The following is a description of a gene set: Human Gene Set: GOBP_NEGATIVE_REGULATION_OF_RNA_METABOLIC_PROCESS Any process that stops, prevents, or reduces the frequency, rate or extent of the chemical reactions and pathways involving RNA. studied in species Homo sapiens, and this is the list of marker genes: ZNF425, NR1H3, ZFHX3, PFDN5, TRIB1, CREG1, CAV1, BRCA1, ZMYM2, DNAJB5, TBR1, RBM42, ALX1, ACTRT1, MORC1 (NCBI Gene Id 27136), SOX4, OTP, ZNF589, TAL1, TXNIP, POU3F3, KLF5, HCLS1, NR2C1, CRY1, CUL3, TAF9B, RNH1, IKZF4, TLE3, TWIST1, TRPV4, MEPCE, FOXP3, PRDM6, PTPN2, JUN, ZNF254, OGT, USP2, PARP14, HOXB13, HEYL, FBLL1, RBM10, TENT4B, DMAP1, MAGEA11, SOX13, CBX2 (NCBI Gene Id 876), SRSF4, ZNF536, IGF2BP2, BCL6B, CITED1, ZHX3, PITX2, ZNF205, NUDT16, GATA1, IGBP1, CCND1, ZFP36, ZNF559-ZNF177, ZBTB20, IL4, DEAF1, MYC, TSHZ3, YBX3, MBD3, HHEX, RBM15B, CIPC, ATF5, ZNF777, WWTR1, ZNF140, PLK1, BRD7, MAGEA2B, HOXA2, NR2F6, TBL1XR1, EP300, FOXC1, YWHAQ, HAND1 (NCBI Gene Id 9421), HNRNPL, MEN1, HES5, JARID2, ZC3H8, SOX7, CTBP1, MYOZ2, ESR2, RBPJ, KAT6A, MAGED4B, FOXH1, TRIM29, RBL1, SMAD3, MIER1, DAZL, ZBTB8A, APBB2 (amyloid beta precursor protein binding family B member 2), SIX5, MAGEA1 (NCBI Gene Id 8271), RBBP4, MTDH, SLIRP, ASCL1, CHD8, LARP1, MAGEA4, HOXB3, NFIL3, SPINDOC, IMPACT, TLE7, CD38, SPEN, L3MBTL2, GLIS3 (GLIS family zinc finger 3, NCBI Gene Id 648268), JPH2, HDAC3, WWP2, YWHAZ, LANCL2, CDX4, PRAMEF9, DLX1, TPR (NCBI Gene Id 7175), RIOX1, SFRP4, LMCD1, ZBTB38, SMO, ZBTB33, TRDMT1, CDKN1C, SINHCAF, MCPH1 (microcephalin 1), MTA3, BCOR, PRICKLE1, IKBKE, CDY2B, CBFB, DDX54, AMOTL2, PKP3, ZNF217, USP9X, ATF3, NPAS1, MAGEA9, KDM8, PARP9, RARA, ZNF263, BMP6, PDE2A, TENT2, HOPX, BASP1, TBL1Y, ZAR1 (NCBI Gene Id 326340), TNF, PRDM12, TBX22, PAWR, MAGEA8, ZIC2, TBX15, HDGF, DCAF1, ZNF85, IRF7, HOXB8, MBD3L3, SREBF2, FLYWCH1, SKOR1, MXI1, PRAMEF12, RTF1, KLF10, SMARCA2, SUPT4H1, BCLAF1, SPI1, MBD3L2B, PAX9, LARP7, KLF3, AXIN2, HEY1, KAT2B, NFIB, SRF, ATP8B1, NKX6-2, NONO, ZMYND8, MAFG, PHC3, SIAH2, EID2B, NFATC4, HNRNPA0, WWC2, BHLHE41, ZBTB32, IRF2, POU1F1, CDK6 (NCBI Gene Id 1021), PABPC1, NPAT, MAX, HOXC8, MAGEA6, PAIP1, MIR128-1, SHH, TRIM11, ATXN1, ZKSCAN3, NMNAT1, SUV39H2, LDB2, NKX6-1, SETD5, SFMBT2, TFEC, WWP1, DMRT1, CENPF, TNFSF11, PRDM8, ACTR6, CEBPB, SFPQ, CDY2A, PAX5, ETV6, BMP7, SCRT1, PHF19, EZR, SHOX2, EED, FOXL2, PHF24, SNAI1, ZMYM5, ZBTB14, PPM1F, HSPA1A, DICER1, ZNF219, WWC1, TFAP2C, PRAMEF22, DNAJB4, SIRT6, SARNP, KAT14, LIMD1, GPS2, SBNO2, CRYM, ELAVL1, RIF1, MIER3, SIX3, HNRNPC, CTNNBIP1, CIC, SMAD2, MAFF, PSMD10, MAGEA10, PRDM1, RBM20, YAF2, ENO1, SP100, BTAF1, MAF (NCBI Gene Id 4094), ARID5A, RN7SK (RNA component of 7SK nuclear ribonucleoprotein), SDR16C5, TRIM6, PSPC1, TCF21, CNOT1, ARK2N, ZNF177, PRKN, LEF1, CXXC5, FZD1, NR2C2, CELA1, SMARCA5 (SWI/SNF related, matrix associated, actin dependent regulator of chromatin, subfamily a, member 5), SOX10, NBAS, TRAF3IP2, PCBP4, CIR1, VSX2, TAF3, LMO4, THRA, ZNF282, ZNF281, YWHAB, TFAP4, SFSWAP, CHD4, ZNF174, BAZ2A, FNIP2, CC2D1B, VEGFA, KDM2B, RBM38, VHL, SRSF1, CDK2, SCAF8, ZNF93, BHLHE40, ZBTB2, SATB1, QKI, SP5, BEND5 (BEN domain containing 5), IRX1, STRN3, SRSF2, HDAC4, FOXO3, DEPDC1, FOXG1, HMX1, FOXR1, PRDM14, SIN3A, SNCA, ZNF512B, CTBP2, GATAD2A, VAX2, CREB1, PEG3, HDAC9, HNRNPD, GLIS1, FOXC2, AR, COMMD7, RNF168, SMURF2, HMGB1, BPTF, AJUBA, POU4F1, IRF1, SUV39H1, WTIP, ZC3H14, JUND, CPEB3, RORC (RAR related orphan receptor C), NEUROG3, MAP2K5, SETDB2, MAD2L2, FUS, FOXD1, POU2F1, WFS1, MXD3, EPO, NELFB, NR1D1, ZP3, HINFP, TOB1, ZNF12, FASLG, FOXM1, CIITA, GATAD2B, TBX2, ZHX2, UBE2D1 (ubiquitin conjugating enzyme E2 D1), MAGEA2, ZBTB18, HES1, PPM1A, ZFTA, SMARCE1, BRMS1L, FOXJ1, ZNF296, PLA2G10 (NCBI Gene Id 8399), PAX2, ISL1, TWIST2, PRAMEF18 (NCBI Gene Id 391003), LRPPRC, TET1, KLF11, ZNF304, MAP3K10, ETS2, SOX1, ZNF608, NRARP, ANKRD2, FZD6, DND1, CTR9, SRC, NSD1, KMT5A, MESP1, SOX8, ZBTB16, TRIM37, TADA3 (transcriptional adaptor 3), RUNX2, SCML1, E2F8, EZH2 (enhancer of zeste 2 polycomb repressive complex 2 subunit), L3MBTL1, NFATC3, TARDBP, TRIM22, MAGEB6B, EN1, HIF1AN, TENT4A, PHB1, ZBTB4, PRAMEF19, SOX6, FEZF1, PKIG, NFATC2, SOX21, IRF2BP1, E4F1, DDX20, HNF4A, ANKRD1, XBP1, ZBTB34, SET, RELA, PRDM13, DNMT3B (DNA methyltransferase 3 beta), GATA4, YY1, CDK5R1, MYOCD, PCGF2, DEDD, RORB, RFX3, TCF7, CIRBP, DUSP22, SPDEF, TRERF1, TRAF2, CAPN3, ZNF175, MED25, MAGEB17 (NCBI Gene Id 652862), PPP1CA, KLF2, SOX3, PBXIP1, POU6F1 (POU class 6 homeobox 1), ARID5B, SSX1, SOX9 (SRY-box transcription factor 9), ZCCHC17, FST, PAF1, ZNF438, FOSB, MOSPD1, SUMO1, KDM4A, GATA5, ATOH8, CRY2, NAB1, BAHD1, MAGEC2, IFI16, CUX1, RBBP7, BCORL1, MAGEB1, NR1I3, SIRT1, SHC1, CHD3, L3MBTL4, EID2, GATA6, APOBEC3A, THAP5, MDFI, DKC1, RNF2, BCL3 (BCL3 transcription coactivator), NR0B2, VPS72 (vacuolar protein sorting 72 homolog), MXD4, TENM2, SCMH1, APOBEC3B, THAP7, HNRNPAB (heterogeneous nuclear ribonucleoprotein A/B), HMGA2, MEF2A, CDYL2, HIVEP1, CNOT2, HEXIM1, NUPR2, TBXT, KLF12, TGIF2LY, THRB, THAP1, WNT5A, RASD1, TLE1, PML, ZBTB25, AURKB, MTA2, DKK3, MEIS2, MTA1, HEY2, SCRT2 (scratch family transcriptional repressor 2), DNAJB1, PPARD, NR1H4, ZNF692, DNAJB6, ZGLP1, ATF7, LEFTY1, MAGEA9B, HMBOX1, BACH2, FOXN3, CUX2, FBLN5, GREM1, CASP8AP2, NCOA2, N4BP2L2, IRX4, CCND3, LHX9, HES6, RITA1, FOXK2 (NCBI Gene Id 84213), ZNF451, MECP2, LIMS1 (LIM zinc finger domain containing 1), PAX6, IRF8, MBIP, SMYD1, NELFA, RIPPLY1, CALCA (NCBI Gene Id 87044), MAGEB5, ING4, ZNHIT1, SCAI, PRDM2, TFCP2L1, IGF2, PPHLN1, MAFK, KHDRBS1, ZNF397, FOXA2, HDAC6, CTCF, ZNF318, NFE2L3, DLL4, DRAP1, HEXIM2, NR2F1, NAF1, NFX1, TAF1, SFRP1, ELK3, PRAMEF26, PIAS1, NR1I2, IGF2BP1, PTBP1, CREBBP, ZNF675, GLI2, MAPK14, LHX1, DAZ4 (NCBI Gene Id 57135), MAGEB3, SIRT2, EZH1, APP, SIM2, SCAF4, AEBP2, HSF1, L3MBTL3 (NCBI Gene Id 84456), ASCL3, KDM5C, PARP10, RCOR3, KLF16 (NCBI Gene Id 83855), NODAL, CDKN2A, ZNF668, SKI, PSMC5, NACA, MZF1, SDCBP, LYAR, PRDM11, RPL23, ESR1, MMP12, COPS2, NANOG, CBX3, NFKB1, PHC2, NSMCE3, TRPV1, PCGF6, PURA, DDX5 (DEAD-box helicase 5), HIC2, PDCD4, SATB2 (SATB homeobox 2), ZNF683, FHL2, PTPRC, MORC3, TAF7, TBX18, RNF8, NFIC, EPC1, DACH1 (NCBI Gene Id 1602), OSR1, AICDA, ZNF431, SOX14, MBD2, E2F7, NCK2, SUMO4, RBM24, NOP53, FOXP1, ZNF750, TENT5A, PER2, RPS14, NELFCD, DHX9, ZNF136, ZBTB49, NCOR2, IFNL1, TDG, PRAMEF13 (NCBI Gene Id 400736), TBX3, TCEAL7, ZNF568, DAB2IP, MAGEF1, NDN, NR2E3, ACE2, ZSCAN10, FAM220A, SIRT7, BCL6, IKZF1, ZBTB17, FOXK1, PRDM5, METTL1, MAGEB10, ZFP90, FOXF1, MBTD1, PPP1R10, ZNF423, RERE, HSBP1, RIPPLY3, H3C13, YAP1, PRAMEF17, ELAVL4, LMO1, ZMYND15, RUNX1, MYBBP1A, MAGEE1, PTPRK, PRAMEF33, RCOR2 (NCBI Gene Id 283248), RB1, WT1, NR1H2, NOSTRIN, MAPKAPK2, PRAMEF14, DDIT3, DACT1, CREM, BAP1 (BRCA1 associated deubiquitinase 1), TBL1X, FAM220BP, ZBED2, UBE2I, IRF2BPL, MBD3L1, ING2, KDM1A, UBE2D3, ATXN1L, SOX15, SAP130, KLF8, EHMT1, E2F6 (NCBI Gene Id 1876), HAMP, PCGF1, PER1, CDY1B, NACC2, RSF1, MDM4, BOLL, CDYL, CNOT7, ZC3H12A, SOX2, MYOZ1, XPO1, TLE5, MACROH2A2, NCK1, CGGBP1, CALR, ZBTB12, TBX20, PRAMEF7, ERN2, ZNF256, PRNP, BMI1, DR1, PROP1, ATF2, TMPRSS6, EAPP, SMYD2, MED1, NR0B1 (nuclear receptor subfamily 0 group B member 1), MEIOC, DMBX1, PPARA, HELT, SIX4, HR, ZNF224, HSPA8, CBY1, MNT, ZFP92, DAB2, PRMT6, NRIP1, SCGB1A1 (NCBI Gene Id 7356), REST, TRIM28, ZNF639 (NCBI Gene Id 51193), DNAJA3, SNW1, H3C14, FOXE1, NPM1, DHX34, EDN1, RBMX, PRDM16, SMAD7, INPP5K, UPF3A, CCNE1, GCLC, IGF2BP3, RARG, APOBEC3C, MAGEA12, BMAL1, VGLL4, ELF3, INSM1 (NCBI Gene Id 8196), SOX18, AHR, FGF9, FOXO1, OLIG3, ZNF703, CDC73, PRAMEF4, MAGEL2, MACROH2A1, WNT10B, OVOL1, MAGED2, FABP4, FCN3, ZNF24, ESX1, TOB2, NOCT, IRF3, WDTC1, TFDP2, CBX8, TBX6, SAP30, ZNF148, ZNF274, E2F1, MBD3L2, CDK5, ID4, ARID4A, TENT5B, LIN37, APOBEC3H, TNP1, PHF12, HIC1, ZNF541, KAT5, POU5F1, CCAR2, EHMT2, SRSF7, ELANE, FOXA1, RFX5, DAZ1, ARID4B, ZC3H6, NKX3-2, ANGEL2, HOXB4, BTG2, ZBTB7B, NR2F2, RARB, CEBPA, LOXL2, CITED2, NFIX, HES2, VDR, NOTCH3, FBP1, ZNF133, RLIM, CSDE1, SORBS3, GZF1, ZNF8, HDAC7, SKIL, MAGEA3, PCNA, ZNF134, PRAMEF8, HSF5, NR4A2, PRAMEF2, VIP, PRMT5, KCNIP3, IREB2, ZBTB10, KCTD1, SAMD11, ZGPAT, CREB3L1, MYT1L, CBX6, SMARCC2, RECQL5, QARS1 (glutaminyl-tRNA synthetase 1), CBFA2T3, SOX12, TCERG1, SOX30, PHF14, MAGEE2, PHF21A, H1-5, KLF7, APOBEC3F, APBB1 (amyloid beta precursor protein binding family B member 1), BCL11A, CCAR1, SRSF6, UXT, TCFL5, HES7, ZEB1, AEBP1, DLX2, NICOL1, RBFOX2, MBD3L4, SF1, LBH, NAB2, NR2E1, RIOX2, ASAH1, TFAP2A, ARX, MAGEB16, PRRX1, SARS1, CTNNB1, BTRC, NELFE, POU4F2, HDAC1 (histone deacetylase 1), PWP1, TRIM33, NOTCH4 (NCBI Gene Id 4855), SOX11, RALY, ZNF366 (zinc finger protein 366), NKAP, NDUFA13, PASD1, COQ7, PDGFB, GATA2, BAG4, THAP11, TRIM27, MAF1, ZNF253, PPID, SGF29, CDKN1B, CDY1, GFI1, ZEB2 (NCBI Gene Id 9839), SFN, SNAI3, WDR82, PATZ1, KAT6B, HOXA7, BIN1, PHB2, TP53, NR1D2, RXRA, EN2, MSC, DNMT3L, DEDD2, CBX1, ZNF239, UIMC1, SALL4, CC2D1A, TIMELESS, SIK1, EOMES, JAZF1, MLIP, RUNX3, HMGB2, PER3, ASCL2, ZC3H4, ZFPM2, TSG101 (tumor susceptibility 101), CREBZF, RPL10, RUNX1T1, TGIF1, MBD3L5, MAGED4, EDNRB, MLXIPL, TP63, SCX, RCOR1, TRPS1, HMGA1, MIER2, TLE6, MDFIC, GATA3, DLG1, TENT5D, HBZ, LOXL3, BIRC5, PCBP3, KAT2A, TCF7L2, NCOR1, RNPS1, TGIF2LX, ZBTB26, ZHX1, MAGEB2, MYD88, PRAMEF6, DHX36, AASS, STAT1, MEF2C, NOTCH1, IL33, LEP, PRAMEF11, TRIB3, SIX1, GAS6, EGR1, ETV5, BRMS1, XRCC5, ID3, SRSF9, FERD3L, FNIP1, SMAD4, ERF, PPP1R13L, MAFB, NCOA5, IRX3, STAT3, PRAMEF5, SCML2, PROX1, HNRNPK, MAGEB18, RING1, CNBP, ANXA4, ZNF354C (zinc finger protein 354C), MSX1 (NCBI Gene Id 4487), URI1 (NCBI Gene Id 8725), UHRF1, SMARCA4, TLE2, S100A1, PIAS4, STAT6, PRDX5, DNMT3A, CRYAB, NR3C1, SYNCRIP, DAZ2, SUDS3, FOXD3, RFC1, MXD1, HDAC2, NACC1, PHAX, XCL1, CBX5, PLK3, CREBRF, KANK2, HCFC2, NOTCH2, NRIP2, NRG1, SREBF1, MITF, ZNF354B, SRSF10, ZMYND11, PARP1, THRAP3, KDM5B, HESX1, SQSTM1, PDX1, PPARG (peroxisome proliferator activated receptor gamma), RUVBL2, ZNF706, BARD1, RELB, RBM47, NSD2, DYRK1A, MAGEH1, ZNF827, SMAD5, ACVR2B, RPS6KA5, FAM76B, KEAP1, H1-2, ZNF268, PKIA, PA2G4, DAXX, SAP18, H1-3, SCML4, HSF4, JDP2 (NCBI Gene Id 122953), SNX6, GSTP1, HDAC5, MTERF3, H3C15, METTL16, MBD1 (methyl-CpG binding domain protein 1), FOXS1, TMBIM6, SMTNL1, PKP1, PRAMEF25, ZNF396, CDX2, MYB, GABPA, ZNF202, GLI3, ZNF540, RIPPLY2, PTCH1, FRK, BATF3, MAGEA13P, IFI27, PSEN1, WWC3, RBM15, HNF1B (HNF1 homeobox B), ZBED6, GDNF, CEBPD, TRAF6, YBX1, MLX, BEND6, ETV3, ZFPM1, MDM2, FOXP2, SP3, MUC1, MYPOP, TAGLN3, FLNA, XRCC6, CIART, BARX2, C1D, TCF3, ZNF418, DPF2, HSBP1L1, ATF4, FGFR2, APOBEC1, METTL14, TENT5C, CCDC85B, MNX1, ZBTB7A, PLAGL1, ZNF350, TCF23, SUZ12, LILRB4 (leukocyte immunoglobulin like receptor B4), RBM46 (RNA binding motif protein 46), PRMT2, EID1, ADIPOQ (NCBI Gene Id 9370), YEATS2, TRIM24 (tripartite motif containing 24), HOXD8, EREG, TGFB1, RREB1, TDP2, CBX4, OLIG2, GADD45A, NIPBL, SAMD7, ZBTB1, BACH1, SAP30L, MYF6, ZNF488, SFMBT1, IFNA2, CBFA2T2, GSC, ZBTB37, LDB1, ZNF141, OSR2, ILF3, PHC1, PARN, ACIN1, HJV, ZBTB21, ZBTB5, KCTD15, DAZ3, KLF4, ENG, ZBTB39, PRAME, ATF7IP, TFAP2B, MAGED1, ZBTB45, GMNN, SUFU, ID1, GFI1B, PARP15, CBX7, A1CF, ELK4, MSX2, PURB, NKX6-3, RYBP, HNRNPU, NR6A1, RRP8, FOXQ1, TSC22D4, IRX2, SP2, SEMA4D, LARP1B, FOXP4, TBX21, ESRRA, KDM5A, ZNF469, MECOM, CLOCK, CTNND1, ZBTB6, MAEL, ELF2, HCFC1 (NCBI Gene Id 8267), HMG20A, LARP4B, EFNA1, MAGEB6, WDR5, NRDE2, NKX2-5, ATN1, HDAC10, CSF2, TNFRSF4, NIBAN2, MIDEAS, DNMT1, ING1, RBAK (NCBI Gene Id 57786), ZNF746, NSUN2, SLA2, HIF1A (NCBI Gene Id 3091), SUPT5H, SFRP2, TRAF5, PRAMEF1, SECISBP2, NKRF, TGIF2, KDM2A, OTUD7B, MAGEB4, DUSP15, PRAMEF27, HDAC8, HOXD9, BMP4, APOBEC3G, ZNF653, SNAI2, OVOL2, HIRA, ZNF131, AMOT, NEDD4, ZNF658, ZNF91, H1-4, SRSF12, INSM2, IFNG, PEX14, AXIN1, NOC2L, NKX3-1, ZNF345, MDFIC2, PLCB1, NR4A3, SIN3B, SALL1, GTF2IRD1 (GTF2I repeat domain containing 1, NCBI Gene Id 9569), TAF15, NOG, DKK1, TLE4, KAT8, TIRAP, IKZF5, NFE2L1 (NCBI Gene Id 6937), PHF6, FGFR1, APEX1, DNAJC17, PRAMEF15, CD36, TRO, SLC11A1, APOBEC3D, DLX4, TXN, BCL7A, DUSP26, PRAMEF20, FLCN, GLIS2, C1QBP, ZBTB42, DDX21 (DExD-box helicase 21), LCOR, BMP2, PIAS3, HIPK2, SAMD1, SKOR2, VAX1, FXR1, U2AF2, FOXF2 (NCBI Gene Id 2295), MAGEC3, STRAP, PRAMEF10, RBBP8, NIF3L1, ORC2 (origin recognition complex subunit 2), TNFSF4, ZNF572, TCP10L, BEND3, ETV7, NKX2-1, ZBTB46, LRRFIP1, MAGEC1, FEZF2, POLE3, EIF4ENIF1, CELF4, ZNF503, MAZ, WNT4, NFKBIA, IRF2BP2, PITX1, ID2